The following is a description of a gene set: Binds to and stops, prevents, or reduces the activity of a chloride channel. species: Homo sapiens Human Gene Set: GOMF_CHLORIDE_CHANNEL_INHIBITOR_ACTIVITY, and this is the list of marker genes: STX1A, ANO9 (NCBI Gene Id 338440), VTI1B, STX7, STX8, VAMP8, CFTR